Given this list of marker genes Itgam, Tal1, Pla2g3, Kit (KIT proto-oncogene receptor tyrosine kinase), Gata3, Stat5a, Zfpm1, here is a description of the gene set: studied in species Mus musculus Mouse Gene Set: GOBP_MAST_CELL_DIFFERENTIATION The process in which a relatively unspecialized myeloid precursor cell acquires the specialized features of a mast cell. A mast cell is a cell that is found in almost all tissues containing numerous basophilic granules and capable of releasing large amounts of histamine and heparin upon activation.